The following is a description of a gene set: Reactome Pathway: Activation of APC/C and APC/C:Cdc20 mediated degradation of mitotic proteins This event has been computationally inferred from an event that has been demonstrated in another species.<p>The inference is based on the homology mapping from PANTHER. Briefly, reactions for which all involved PhysicalEntities (in input, output and catalyst) have a mapped orthologue/paralogue (for complexes at least 75% of components must have a mapping) are inferred to the other species. electronically inferred by orthology from the curated human pathway part of: APC/C-mediated degradation of cell cycle proteins studied in species Mus musculus, and this is the list of marker genes: Ccnb1, Rps27a, Psma5, Anapc7, Ccna1, Psmc5 (NCBI Gene Id 19184), Psmb5, Psmd1, Cdk1, Psmd6, Psmb6, Cdc26, Ubb, Anapc15, Psmc2 (NCBI Gene Id 19181), Psmd13, Psma2, Psma4, Psmd12, Psma1, Psmc1, Mad2l1, Psma3, Plk1, Psmc4, Psmc3, Anapc2, Psma6, Cdc23, Psmd7, Psmb7, Psma7, Psmc6, Ube2s (ubiquitin-conjugating enzyme E2S), Ube2e1, Ube2d1, Anapc10, Psmb4, Ube2c